Given this list of marker genes RACK1, SLBP, GTPBP1, ABHD14B, STRIP2, MEFV, UVSSA, NAPSA, GSTT2, RASA4, SELENOH, CENATAC, NFU1, CLN3, HPSE, NCOA3, ASPM, PALD1, SRGAP2, AKNA, EIF4EBP2, SSX2IP, RNF139, MTMR14, ZDHHC13, MGST2, ORC3, CARD10, PDS5A, PTPRC, ZNF281, DUSP2, PDCL3, CYFIP2, POLA2, FASLG, U2AF1, PPP1R12A, EPB41L2, NCAPD3 (non-SMC condensin II complex subunit D3), NUDC, XAB2, LRWD1, TIMP3, CYLD, ZNRF1, SNRPD3, ARHGAP15, ACP2, IL10, DOCK10, IST1, SH3PXD2B, BACH1, NRM, SREBF2, KHNYN, HPS3, GRAMD1C, ST6GALNAC5 (ST6 N-acetylgalactosaminide alpha-2,6-sialyltransferase 5), NGDN, CNOT3, BATF, NICOL1, SCAF11, WDR6, SLC39A4, DLGAP5 (NCBI Gene Id 9787), CCND3, USP25, RAP1GAP2, TMEM86A, BST1, UNC13D, SNAP23, AZI2, CMTR1, HSDL1, STX11, FHL1, CRISPLD2, NDUFA8, PRAM1, OSBPL3 (oxysterol binding protein like 3), FNBP4, PTK2B, MYL10, RPL18A, PTMS, CDKN2D, CD79B, CD28, EPB41L3, SLIRP, CCDC86, CMC2, ARPC4, UBA7 (NCBI Gene Id 7875), FKBP15 (NCBI Gene Id 23307), RFC4, SGSH (NCBI Gene Id 6448), NFKBID, SHISA5, MSH2, SUB1, PAN3, SELENOW, NEDD9, RAB20, RPL23A, STARD4, PSENEN, GNA14, IQGAP3, MRPL45, TOX4, ARL5A, MPHOSPH9, MRPL28, TLK1, PARP3, ATG3 (autophagy related 3), BAZ1A, RAPGEF6, ZNF292, LOXL3, SNRPA1, RNF167, STIL, LIPG, CENPT, HAGHL, RNF157, SERPINB2, CBX3, CENPN, KLF2, IRF3, VTA1, INTS5, GMNN, GPR84, SLC7A7, FILIP1L, GPD2, PPP1R21, CSF1 (NCBI Gene Id 1435), ARHGDIB, DEK, PSMB9, GRK3, IKZF2, SGO1, PAFAH1B3, RPS16, DGKD, CCND2, ATP8B2, SOD1, G6PD, WDR90, CTSW, MAGOHB, MKNK2, ERMARD, SNRPD1, GMIP, IL1RN, TMEM163, CDC6, GPR18 (NCBI Gene Id 2841), TOPBP1, CDC26, RGS10, IMPA2, EMD, ERCC6L, SEC61B (SEC61 translocon subunit beta), PFKM, SUSD6, ATP5MC2 (NCBI Gene Id 517), NCAPG, FBXL4, EZH2, APOD, TMEM131L, PSMA2, FAU, PRPS2, GBP4, MVB12B, BRCA2, PRPSAP1, NEU1, NELFB, NT5C3B, ARHGEF10L, CXCR6, IL1B, POLE, here is a description of the gene set: species: Homo sapiens Human Gene Set: GSE5589_UNSTIM_VS_180MIN_LPS_STIM_MACROPHAGE_DN from publication El Kasmi KC, Holst J, Coffre M, Mielke L, de Pauw A, Lhocine N, Smith AM, Rutschman R, Kaushal D, Shen Y, Suda T, Donnelly RP, Myers MG Jr, Alexander W, Vignali DA, Watowich SS, Ernst M, Hilton DJ, Murray PJ (PMID 17114459) IL-10 or IL-6 stimulation of control 129xC57BL/6 murine bone marrow derived macrophages in the presence of LPS. We used microarrays to detail the global programme of gene expression changes in response to IL-6 or IL-10 stimulation in the presence of lipopolysaccharide. BMDMs were isolated from control, IL-6-/-, and IL-10-/- mice on a 129XBL/6 mixed background mice and differentiated in the presence of CSF-1 for 6-7 days. Cells were scraped and plated in 6 well plates at 2x10e6/well. Cells were washed with complete DMEM and rested for 1-2 hr before stimulation with combinations of IL-10 (10 ng/ml), IL-6 (2 ng/ml) or LPS (100 ng/ml) for 45 min or 180 mins. Complete biological replicates were performed. Genes down-regulated in bone marrow-derived macrophages: untreated (0 min) versus LPS (180 min).